The following is a description of a gene set: studied in species Homo sapiens part of: Neurotransmitter receptors and postsynaptic signal transmission Reactome Pathway: Activation of kainate receptors upon glutamate binding Kainate receptors are found both in the presynaptc terminals and the postsynaptic neurons. <br>Kainate receptor activation could lead to either ionotropic activity (influx of Ca2+ or Na+ and K+) in the postsynaptic neuron or coupling of the receptor with G proteins in the presynaptic and the postsynaptic neurons. <br>Kainate receptors are tetramers made from subunits GRIK1-5 or GluR5-7 and KA1-2. Activation of kainate receptors made from GRIK1 or KA2 release Ca2+ from the intracellular stores in a G protein-dependent manner. The G protein involved in this process is sensitive to pertussis toxin., and this is the list of marker genes: GNG10, GRIK2, GNG3, GRIK3, PLCB1, GNG2, GRIK1, CALM1 (NCBI Gene Id 801), GNB2, GNG11, GNG5, GNGT1, GNG13, GRIK5, GNB1, GNGT2, GNG12, NCALD, PLCB2, PLCB3, GRIK4, GNB5, GNB4 (G protein subunit beta 4), DLG3, DLG4, DLG1, GNG4, GNG7, GNG8, GNB3